Given this list of marker genes TMEM106A, GNA13, KAT2B, SLC13A1, PDZK1IP1, ARHGEF3, ALPK2, KRT1, DBR1, EPHA1, NANOG, CCDC6, NKG7, MCMBP, MRPS28, NOS2 (NCBI Gene Id 4843), MARK4, KCNA6, CRBN, VRK2, CPSF2, CRYM, CD300LF, GBP4, FBRS, AGTRAP, MTMR7, MUTYH (NCBI Gene Id 4595), PTGES, SERPINA3, ARF6, BFSP1, APPBP2, ITGB3, FST, TAL1, LCAT, ECE2, KCTD4, CHIC2, MMP14, RILPL1, IRGM, BCKDHB, PHC2, FASLG, WBP4 (WW domain binding protein 4), CAV1, SFMBT2, PGLYRP1, MZF1, RPS6KA4, CEP350, C18orf21, PALLD, PRPF38B, GCA, CLCF1, CLIP1 (NCBI Gene Id 6249), RALGDS, PTPN23, MTDH, G3BP2, IDS, B3GAT1, NAE1, HOMER1, PARP4, CTRL, MBD2, ACVR1, GTPBP1 (NCBI Gene Id 9567), MAPKAPK2, ATAD1, MAPK6, CLCNKA, NAMPT (nicotinamide phosphoribosyltransferase), GNG11, PPP2R5A, TKFC, CLASP2, RAP2A, MAL, TPR, DUSP2, IFT172, CLK3, NRG3, TAFA5, TAS1R1, SELENOV, MT2A, LZTS2, HACE1, LZTFL1, MTPN, FBXW7, CRISP2, TIMELESS, STARD5, SLC8A1, SERPINB11, ISOC1, DSCAM, GRHL2, ETS2, ROBO1, SEMA3C, SNX2, SCAMP1, P2RY14, GFRA4, CALCR (calcitonin receptor), DDHD1, PRKCD, DMTF1, BRINP1 (BMP/retinoic acid inducible neural specific 1), PPIG, JAM3, STEAP1, PIGF, SYF2, CRABP2, FKBP1A, NUB1, ARID5B, TSTD1, ASB6, IRF8, CACNA1H, ELF3, VDR, COX17, STXBP1, U2SURP, TBX18, C3orf52, OAS2, ICOSLG, IL10RA, ASGR2, TRA2B, IGSF9, MAPKAP1, CAB39L, OAF, POMC, EHD1 (EH domain containing 1), AP1AR, DDX4, YARS1, USP25, EPSTI1, FABP3, TMEM243, CD47, APOD, SOD2, GBP2, PEX13, ASNS, WDR43, TMEM47, HELZ2, XCR1, KEAP1, TYK2, FRYL, UGGT2, PLEKHF2, GK, PAFAH1B2, RNF114, OLR1, PSAPL1, NECAB3, EIF2S1, RAD23A, CPSF4L, FRMD6, LTA, CHTOP, ELMO1, HOXB9, KTN1, TRMT10A, NTSR2, TSPAN33, LPP, STXBP3, ARMCX1, PLAGL2, MTFR2, PLG, ARHGAP6, CALCRL, CCNL1, PDSS1, SH3TC1, here is a description of the gene set: studied in species Homo sapiens Human Gene Set: GSE17721_CTRL_VS_POLYIC_6H_BMDC_DN mouse primary BMDCs were stimulated with tlr ligands and gene expression changes were profiled on Affymetrix arrays from publication Amit I, Garber M, Chevrier N, Leite AP, Donner Y, Eisenhaure T, Guttman M, Grenier JK, Li W, Zuk O, Schubert LA, Birditt B, Shay T, Goren A, Zhang X, Smith Z, Deering R, McDonald RC, Cabili M, Bernstein BE, Rinn JL, Meissner A, Root DE, Hacohen N, Regev A (PMID 19729616) Genes down-regulated in comparison of control dendritic cells (DC) at 6 h versus those stimulated with poly(I:C) (TLR3 agonist) at 6 h.